The following is a description of a gene set: Genes predicted to be targets of miRBase v22 microRNA mmu_miR_3109_5p in miRDB v6.0 with MirTarget v4 prediction scores > 80 (high confidence targets). from publication Chen Y, Wang X (PMID 31504780) species: Mus musculus Mouse Gene Set: MIR_3109_5P, and this is the list of marker genes: Ngp, Clic5, Cadm2, Gm5591, Apoe, Ddx3x, Rspo1 (NCBI Gene Id 192199), Clasp1, Snrpn, Usp54, Cep57l1, Hnrnpul1, Olfm3, Akap13, Eln, Sacm1l, Hmgb1, Prokr2, Snrpf, Sntg1, Snurf, Itga1, Ncam2, Rtp2, Ewsr1, Gcnt2, Ccl28, Msrb3, Cbx5, Adam19, Pum2, Pabpc5, Cldn23, Plekha3, Tmem33, Nuak1 (NCBI Gene Id 77976), Fut9 (NCBI Gene Id 14348), Acer1, Or12j5, Fam149b, Hnrnpll, Gsg1l, Cks2, Slc24a3, Trpc6, Mbtps2, Aqp9, Cd300a, Negr1, Luc7l2, Fam135a, Yars2, Tbc1d12, Cldn18